Given this list of marker genes Drd2, Crhbp, Oprm1, Unc79, Dbh, Chrna7, Aldh2, Fgf2, Usp46, Eps8, Crhr1, Adh1, here is a description of the gene set: studied in species Mus musculus Mouse Gene Set: GOBP_BEHAVIORAL_RESPONSE_TO_ETHANOL Any process that results in a change in the behavior of an organism as a result of an ethanol stimulus.